Given this list of marker genes LAMTOR3, CRYZP2, FAM177A1P1, MTTP, DNAJB14, ADH7, RAP1GDS1, METAP1, RPL7L1P14 (RPL7L1 pseudogene 14), H2AZ1-DT, TSPAN5, TBCAP3, C4orf17, H2AZ1, EIF4E, BTF3P13, TRMT10A, DYNLL1P6, ADH1B, STPG2, ADH1C, RPL5P12, C4orf54, ADH6 (NCBI Gene Id 130), DAPP1, MIR3684, TSPAN5-DT (NCBI Gene Id 112267901), RNU7-149P, RPL21P48, DUTP8, ADH4, ADH1A, PCNAP1, NDUFS5P4 (NADH:ubiquinone oxidoreductase subunit S5 pseudogene 4), ABT1P1, ENSG00000246090, ADH5, here is a description of the gene set: Human Gene Set: chr4q23 studied in species Homo sapiens